The following is a description of a gene set: studied in species Homo sapiens Any process that decreases the rate, frequency or extent of the SMAD protein signaling pathway. Human Gene Set: GOBP_NEGATIVE_REGULATION_OF_SMAD_PROTEIN_SIGNAL_TRANSDUCTION, and this is the list of marker genes: EID2, SMAD6, PIN1, CILP, DKK1, ENG, MIR204, MIR145, GDF15, GREM1, MIR26A1, UCMA, TGFBR3, MIRLET7G (microRNA let-7g), OVOL2, MIR26B, MIR101-1, SMAD7, MIR195, CCN3, MIR199A1, XBP1, MIR27A, NOG, PMEPA1, PPARG, EMILIN1, MIR140, LRP1, FAM89B, MIR130A, SKI, CRKL, MIR23A, LDLRAD4, MIR885, MIR323A, TBX20, MIR146A, MIR205, MIR483, VEPH1